Given this list of marker genes TRIM32, CD74, ELL3, BCL2, CD44, ING2, KDM1A, ZNF385A, CCAR2, TAF9B, DDIAS, BCL2L12, USP47, TRIAP1, CLU, BCL2L1, MIF, TMEM161A, TAF9, MUC1, SFRP2, ACKR3, ATAD5, SIRT1, SNAI1, SNAI2, TPT1, BID, CDKN2D, MARCHF7, CXCL12, here is a description of the gene set: studied in species Homo sapiens Human Gene Set: GOBP_NEGATIVE_REGULATION_OF_INTRINSIC_APOPTOTIC_SIGNALING_PATHWAY_IN_RESPONSE_TO_DNA_DAMAGE Any process that stops, prevents or reduces the frequency, rate or extent of intrinsic apoptotic signaling pathway in response to DNA damage.